Given this list of marker genes Icam2, Lmo4 (NCBI Gene Id 16911), Dynll2, Pfdn5, Stmp1, H2az2, Stub1, Bloc1s1, Rpl21, Blvrb, Ifitm3, Arl4a, Vps29, Rpl18a, Sub1, Nme2, Pop5, Cotl1, Lamtor2, Mien1, B2m, Cmip, Ralbp1, Eng, Srrm2, Tubb5, Thap3, Ctdnep1, Eif1ax, Hnrnpa0, Ift20, Gid4, Ndufs8, Crip2, Rpl34-ps1, Nfic, Stmn1 (stathmin 1), Tbcb, S100a13, Rala, Ftl1, Ssbp3, Cfl1, Tenm2, Zfpl1, Hspe1, Coro1a, Uqcrq, Palld, Tpt1, Chmp2a, Ndufb8, Irag2, Mrpl17, Rps3a1, Mzt2, Psmb1, Magoh, Atp5mc3, Prr13, Fam241b, Plekhj1, Adh1, Sh3pxd2a, Nop10 (NOP10 ribonucleoprotein), B4galt1, Rnase4, Set (NCBI Gene Id 80406), Acin1 (apoptotic chromatin condensation inducer 1, NCBI Gene Id 97920), Grem1, Arhgdib, Psma2, Ubb-ps, Ybx1, D8Ertd738e, Srp14, Cnp, Igfbp7, Rtraf, Gps2, Acbd6, Trem2, Klf2, 1110038F14Rik, Grcc10, Trnau1ap, Ndufb4, Arhgap44, Ly6e, Rps20, Atp5mg, Tsn, Rps16, Mpo, C1d, Ndufc2, Cox7a2l, Chi3l1, Rplp0, Sod1, Enpp2, Polr2f, Tra2a, Fabp5, Ptma, Krt17, Ctss, Tma7, Lhx2, Fkbp2, Cdk2ap2, Ndufa5, Polr3gl, Emd, Ino80b, Wdtc1, Cyba, Cox4i1, Bmyc, Akt1s1, Gpx1, S100a4, Cdkn1c, Mrpl58, Bcl9l, Timp3, Sec61b, Mrpl51, Rpl32, Rex1bd, Fam89b, Furin (furin, paired basic amino acid cleaving enzyme), Hoxc8, Macrod1, Mpv17l2 (MPV17 mitochondrial membrane protein-like 2), Atp5pf, Tceal9, Vps28, Cck, Rps27a, Tmem219, Rabac1, Tagln, Trappc3, Rps5 (NCBI Gene Id 20103), Sdhc, Ndufb10, Plpp3, Hoxa7, Cd14, Mrpl13, Ndufs6, Ctbp2, Psme1, Higd2a, Ranbp1, Lrrc8a (leucine rich repeat containing 8A VRAC subunit A), Fermt1, Eif3g, Dnajc8, Serpinf1, Mrpl33, Snrpd1, Mtarc2, Mrps12, Psmb6, Gadd45b (growth arrest and DNA-damage-inducible 45 beta), Cfdp1, Etfb, Drap1, Psmb4, Vamp8, 2310011J03Rik, Mag, Ubb, Dad1, Ifi27, Ndufa12, Nudt3, Snrpc, Pdgfa, Wbp2, H2-Ab1, Calm3, Ndufv2 (NCBI Gene Id 72900), Chd4, Tex261, Alkbh6, Phpt1, Lck, Npc2, Ebna1bp2, Apoe, Ift27, Cox6b1, Cnpy2, Psenen, Pold4, Ceacam1, Micos13, Rnf126, Pabpn1, Atp6v1g1, Csnk2b, Siva1, Rps18, Ece1, Timm13 (NCBI Gene Id 52584), Ptms, Mpc1, Cnih4, Rps24, Bola2, Nsd3, Emc10, Ndufs3, Sumo1, Hoxb2, Rnaset2b, Hypk, Capns2, Igfbp6, Egfl7, Stx8, Mrpl14 (NCBI Gene Id 68463), Anapc11, Dctn4, Atp5mc1, Ppp1r11, Nrtn, Sf3b2, H2-K1, Tmem222, Trf, Clta, Tmed10, Arl13b, Sox9, Capg, Sox17, Tmem204, Atp5if1, Pcbp2, Cycs, Gstm1, Cib2, Mrps15, Ifitm2, Hopx, Dctpp1, Rps14, Rps8, Gimap6, Ndufb11, Dynll1, 2210016L21Rik, Gabarapl2, Oaz1, Rpl12, Kcnk2, Polr2e, Rpl9, Mrpl18, Ly6a, S100a16, Gas5, Hmgn1, Bcr, Tpm2 (tropomyosin 2, beta), Gstm5, Rpl24, Scand1, Timm17b, Dcxr, Pfdn2, Ctsl, Gnptg, Exosc7, Cope, Manf, Mrpl27, Lgals3bp, Ndufb9, Klhl9 (kelch-like 9), Pdrg1, Pstk, Klf4 (Kruppel-like transcription factor 4 (gut)), Cpne8, Nenf, Rpl17, Cytl1, Prxl2a, Rplp1 (NCBI Gene Id 80450), Ppp1r35, Pfn1, Ddrgk1, Rbm8a, Ndufs4, Calm2, Ldhb, Capns1, Thbd (NCBI Gene Id 98935), Mrpl48, Smim30, Lgr4, Vps72, Gstp1, Krt18, Hint1 (histidine triad nucleotide binding protein 1), Vim, Lgals1, Ndufab1, Dpy30, Spag7, Rpl14 (NCBI Gene Id 67115), Rpl23, Micu3, Ube2m, Tmed1, Npm1, Adrm1, Esam, Dpt (dermatopontin), Ly6d, Rbm26, Mmp24os1, Rps15a, Ubxn4, Ypel3, Ppp1r9b, Cdpf1, Rpl5, Znhit6 (zinc finger, HIT type 6), Mrpl22, BC064078, Sh3bgrl3, Cd63, Trmt112, Ctnnbip1, Tmbim4, Cox8a, Ten1, Tmsb10, Rps7, Eef1b2, Pqbp1, Mrps16, Lefty1, Nudt9, Igfbp5, Cbr2, Krtcap2, Myl9, Rps15, Naxe, Bad, Gemin7, Snrpb, Pttg1 (pituitary tumor-transforming gene 1), Serbp1, Alad, Aurkaip1, Tmem205, Rbm39, Hmgb2, Cnn3, Eif3f, Adh7, Rtf1, Zfp703, Uqcrh, Smco4, Ncl, Naa10, Vcf1, Cxcl14, Ddr1, Vti1b, Clic1, Ly6c1, Eef1d, Crip1, Psmb5, Mrpl41, Lxn, Txndc17, Ppib, Brk1, Ndufa4, Endog, Eci1, Use1, Rps12, Sra1 (NCBI Gene Id 24068), Sem1, Apoc1 (NCBI Gene Id 11812), Rpl19, Rpl18, Psma7, Clic4, Sparcl1, Iffo2, Sarnp, Sdc4, Tmem250, Gtf2h5, Rpl8, Ebpl, Hsbp1, Rpl10a, Lmo1 (LIM domain only 1), Hoxb6, Cyb5a, Zfp36l1, Cox6a1, Psmd4, Tm2d3, Ndufa13, Zmat5, Hint2 (histidine triad nucleotide binding protein 2), Nme1, Rpl7a, Krt14, Nol7, Arl2 (NCBI Gene Id 80563), Cirbp, Lgals9, Selenom, Ndufs7, Frg1, Mrpl30, Mgp, 0610010K14Rik, Sf3b4, Ccdc28b, Senp6, Eif1b, Erh, Rpl36, Tm2d2 (TM2 domain containing 2), Arl6ip5, Snw1, Cenpx, Nfix, Spry2, Lrp4, Srrm1 (serine/arginine repetitive matrix 1), Krt4 (keratin 4), Nfkbib, Btf3, Zfp664, Rexo2, Lage3, Gatad1 (NCBI Gene Id 77497), Ndufb7, Ethe1, Sparc, C1qbp, Cmtm7, Swi5, Sf3b5, Rrn3, Rps3 (ribosomal protein S3), Atraid, Eif5a, Brd2, Txn2, U2af1, Rpl10, Pebp1, Dut, Mgst1, Arglu1, Birc6, BC031181, BC005624, Cd9, Spcs1, Rwdd1, Svbp, Myl12a, H2-Aa, Ndufc1, Mbp, H2aj, Phyhipl, Col3a1, Zmat2, Ino80e, Atp5f1d, Samd4b (sterile alpha motif domain containing 4B), Fis1, Hmgb1, Gpx4, Tspo, Luzp1, Zfp503, Tmem9, Cst3, Gnb1, Nbl1, Polr1d, Pfdn6, Ube2l3, Tmem126a, Rarg, Irf2bp2, Rpl3, A430005L14Rik, Arf5, Lin37, Prdx5 (peroxiredoxin 5), Emc4, Ier3, Ccdc85b, Atp5mc2, Ufc1, Chchd2, Med10, Cited2, Psme2, Cd74, Gabarap, Krt8, Pfdn1, Flna, Dcn, Bcl7c, Qsox1, Rplp2, Slpi, Kpna4, Lrg1, Fkbp3, Dtx3, Hs3st6, Snrpd2, Pdzk1ip1, Atp5mf, Kif1c, Acta2, Glrx5, Wbp4, Rps19, Cavin3, H2-Eb1, H2-D1, Rack1, Tmem107, Tmem242, Eif4g1, Naa80, Rpl35, Tmem234, Reep5 (NCBI Gene Id 98127), Tnfaip8, 2510002D24Rik, Rpsa, Rpl11, Cdc42ep3, Npm3 (nucleoplasmin 3), Tfap2b, Mrpl24, Dctn3, Psma6, Arhgdia, Wbp11, Mydgf, Srsf5, Snrnp27, Sde2, Uqcr10, Arl3 (NCBI Gene Id 56350), Bcl2l12, Id3, Mpc2, Mrpl28, Spsb2, Syf2, Rpl37a, Nectin1, Usp18, Ndufa8, Spr, Rdh13, Gadd45gip1, Mrpl42, Fgfbp1, Trappc6a, Ddah2, Dynlrb1, Znrd2, Elof1, Try5, Mrpl12, Rflnb, Nop53, Cfap298, Lsm4, Rhoc, Malat1, Cstb, Tmem42, Tmem14c (transmembrane protein 14C), Tmem50a, Dtd1, Marcksl1, Nedd8, Szrd1, Banf1, Anp32e, Edf1 (NCBI Gene Id 80387), Anp32a, Cisd1, Phlda3 (NCBI Gene Id 27280), Cltb, Ninj1, Tmed9, Efnb2, Gpx3, S100a14, Gnb2, Mea1, Fcgr3, Pomp, Tcf7l2, Cox5a, Polr2g, Ndufb6, Rp9, Wdr83os, Aprt, Selenos, Tmed3, Otub1, Mrpl54, Kdelr1, Dhrs4, Ube2k, Sec11c, Tssc4, Cic, Tubb6, Mpdu1, Iscu, Atox1, Kdm6b (NCBI Gene Id 216850), Rps27l, Fxyd6, Cbx1, Chrac1, Rps17, Ubald1, Plpp1, Smdt1, Eif3k, Psmb8, Ptgds, Rnasek, Vkorc1, Tmem160, Spin1 (spindlin 1), Erdr1, Bola1, Sumo2, Snrpa, Copz2, Tle5 (TLE family member 5, transcriptional modulator), Polr2i, Gatd3a, Ube2s, Agr2, Ctsz (NCBI Gene Id 99199), Rps11, Rps13, Zfp414, Coa3, Ssr4, Sfrp1, Ppig, Irx5, Fgfr1, Nabp2, Rps4x, Rpl28, Pafah1b3 (NCBI Gene Id 18476), Trir, Bri3, Zcrb1, Rps27 (ribosomal protein S27, NCBI Gene Id 69272), Ier2, Ndufa11, Hsd17b10, Plgrkt, Nudc, Nr4a2, Irx3, Rps10, Fth1, Mrps14, Pdcd5, Naca, Marf1, Pdap1, Rpl13a (ribosomal protein L13A), Psmd7, Wfdc3, Park7, Lamtor4, Commd1, Eif5b (NCBI Gene Id 226982), Tmem11, Wasf2, Cbx3, Atp6v1f, Ltbp4, Twf1, Plp2, Map1lc3a, H2-DMa, Rpl31, Polr1g (RNA polymerase I subunit G), Hpf1, Rpl4, Micos10, Col1a2 (NCBI Gene Id 12843), Rsrc2, Arpc3, Ier5l, Cryab, Fbl, Krt24, Exosc8, Ppp1r13l, Krt19, Gstm2, Skil, Snrpg, Ubl7, Tmem208, Hras, Mrtfb, Fzd2, Pgls, Triap1 (TP53 regulated inhibitor of apoptosis 1), Dnajc4, Ndufb5, Atn1, Ccdc124, Mospd3, Uqcc3, Myl6, Gm2a (NCBI Gene Id 552880), Urah, Psmb3, Nt5c3b, Cbr1, Mycbp2, Rnaseh2c, Phb2, Ap2s1, Ltbp2, Ccdc12, Bsg, Ciao2b, S100a1, Elob, Ppdpf, Mir24-2, Manbal, Snrpd3, Ccdc59 (coiled-coil domain containing 59), Penk, Uvssa, Jtb, Ssna1, Serping1, Chchd7, Eif4ebp1, Cbarp, Tm4sf1, Spint2, Fxyd3, Aldh3a1, Emp3, Lamtor1, Rpl27a, Scx (NCBI Gene Id 20289), Dpm1, Khk, Ostc, Jund, Selenok (selenoprotein K), Sfn, Sin3b, Cxcl1, Znhit1, Laptm5, Dek, Pin1, Paqr6, Arl6ip4, Ubxn1, Zscan26, Mocs2, Ncoa3, Lsm2, Anp32b, Atp6v0c, Med28, Ndufa6, Rpl22, Exosc1, Cldn4, Tfap2a, Pole4, Pltp, Psmb2, Atp5po, Tmsb4x, Uqcc2, Atp6v0e, Rbm25, Rps9, Gga1, Cdc42ep5, Mrpl23, Calm1, Rrp1, Tomm6, Rpl6, Atp5pd, Rras, Naa38, Cald1, Dpysl2, Hmg20b, Hmgn2, Nradd (NCBI Gene Id 67169), Bex3, Rac3, Mif, Serf2, Exosc5, Ifi35, Dgcr6, Klf5 (Kruppel-like transcription factor 5), Mrps24, Rpl13, Selenow, Ndufa7, Rnf208, Ddhd2, Cebpzos, Gng5, Babam1, Aimp1, Prelid1, Pdcl3, Myo1d, Cuta, Apold1, Hcfc1r1, here is a description of the gene set: studied in species Mus musculus from publication Tabula Muris Consortium (PMID 32669714) Mouse Gene Set: TABULA_MURIS_SENIS_SKIN_BULGE_KERATINOCYTE_AGEING